The following is a description of a gene set: The volume enclosed by the membrane of an endosome. Mouse Gene Set: GOCC_ENDOSOME_LUMEN studied in species Mus musculus, and this is the list of marker genes: Cd63, Lrpap1, Hspa8, Il12b, Ctsd, Ngf, Pdlim4, Lrp2 (low density lipoprotein receptor-related protein 2), Prf1, Ide, Il12a, Ctss, Ptpn2, Gapdh, Ptpn1